The following is a description of a gene set: Human Gene Set: GOBP_METANEPHRIC_COLLECTING_DUCT_DEVELOPMENT The process whose specific outcome is the progression of a collecting duct in the metanephros over time, from its formation to the mature structure. The collecting duct responds to vasopressin and aldosterone to regulate water, electrolyte and acid-base balance. The collecting duct is the final common path through which urine flows before entering the ureter and then emptying into the bladder. studied in species Homo sapiens, and this is the list of marker genes: DLG5, PTCH1, WNT7B, SHH, PAX2, CALB1, PAX8, AQP2, AKR1B1, PKD1